The following is a description of a gene set: studied in species Mus musculus Mouse Gene Set: GOBP_SODIUM_ION_IMPORT_ACROSS_PLASMA_MEMBRANE The directed movement of sodium ions from outside of a cell, across the plasma membrane and into the cytosol., and this is the list of marker genes: Slc9a6 (NCBI Gene Id 236794), Slc5a6, Asic5, Scnn1a, Hcn4, Trpm4, Scnn1g, Slc34a1, Slc9a5, Slc12a2, Slc8a1, Slc9a4, Slc9a3, Slc9a1, Slc9a7, Slc9c1, Slc5a2, Ank3, Slc9a9, Slc6a1, Hcn2, Scn5a, Scnn1b, Slc9a2, Slc5a1